The following is a description of a gene set: Pathway Definition from KEGG: TLR3 -> TICAM1 -> TRAF3 -> (IKBKE+TBK1) -> IRF3 -> (CREBBP,EP300) => IFNB1 TLR3-IRF3 signaling pathway. Pathway ID: N00149. Pathway type: Reference. Pathway class: nt06517 TLR signaling. studied in species Homo sapiens Human Gene Set: KEGG_MEDICUS_REFERENCE_TLR3_IRF3_SIGNALING_PATHWAY, and this is the list of marker genes: IFNB1, CREBBP, IKBKE, IRF3, TBK1, TLR3, TRAF3, EP300, TICAM1